The following is a description of a gene set: studied in species Homo sapiens The Fhit tumor suppressor binds and hydrolyses diadenosine polyphosphates and the Fhit-substrate complex has been proposed as a proapoptotic effector, as determined by infection of susceptible cancer cells with adenoviruses carrying wild-type fragile histidine triad (FHIT) or catalytic site mutants. The highly conserved Fhit tyrosine 114 (Y114), within the unstructured loop C-terminal of the catalytic site, can be phosphorylated by Src family tyrosine kinases, although endogenous phospho-Fhit is rarely detected. To explore the importance of Y114 and identify Fhit-mediated signaling events, wild-type and Y114 mutant FHIT-expressing adenoviruses were introduced into two human lung cancer cell lines. Caspase-dependent apoptosis was effectively induced only by wild-type but not Y114 mutant Fhit proteins. By expression profiling of FHIT versus mutant FHIT-infected cells, we found that survivin, an Inhibitor of Apoptosis Protein (IAP) family member, was significantly decreased by wild-type Fhit. In addition, Fhit inhibited activity of Akt, a key effector in the phosphatidylinositol 3-OH kinase (PI3K) pathway; loss of endogenous Fhit expression caused increased Akt activity in vitro and in vivo, and overexpression of constitutively active Akt inhibited Fhit-induced apoptosis. The results indicate that the Fhit Y114 residue plays a critical role in Fhit-induced apoptosis, occurring through inactivation of the PI3K-Akt-survivin signal pathway. from publication Semba S, Trapasso F, Fabbri M, McCorkell KA, Volinia S, Druck T, Iliopoulos D, Pekarsky Y, Ishii H, Garrison PN, Barnes LD, Croce CM, Huebner K (PMID 16407838) Human Gene Set: SEMBA_FHIT_TARGETS_UP Genes up-regulated in H1299 cells (non-small cell lung cancer, NSCLC) expressing the Y144F mutant form of FHIT., and this is the list of marker genes: COL27A1, LY96, ATXN1, COL1A1, IFI44L, ULBP2, HSPD1, OAS1, WDR20, JMY, SPHK1